Given this list of marker genes SLC35A1, RUNX1, HPS6, HPS3, HPS5, GFI1B, HPS4, GATA1 (NCBI Gene Id 2623), AP3B1, BLOC1S5, IKZF5, LYST, NBEAL2, here is a description of the gene set: Human Gene Set: HP_ABNORMAL_PLATELET_GRANULES species: Homo sapiens Abnormal platelet granules An anomaly of alpha or dense granules or platelet lysosomes.